The following is a description of a gene set: studied in species Homo sapiens Genes predicted to be targets of miRBase v22 microRNA hsa-miR-338-5p in miRDB v6.0 with MirTarget v4 prediction scores > 80 (high confidence targets). Human Gene Set: MIR338_5P from publication Chen Y, Wang X (PMID 31504780), and this is the list of marker genes: SLC25A12, ARHGAP12, LRATD1, BMI1, ENAH, ZBTB44, PICALM, CLIP1, DYRK1A, NDUFS2, TLK1, HOXA10 (homeobox A10), SLC25A53, DLGAP1, FRS2, ZFAND5 (NCBI Gene Id 7763), SCN2A, H3-3B, TSHZ3, KALRN, AZIN1, ABTB2, CHSY3, H3-5, CCNL2, OBI1, CNOT4, HSPH1, ATP11C, CAMTA1, ZNF711, SPRY4, HDAC4, SGK1, ATP2C1, ATOSA (NCBI Gene Id 56204), PTPN2, KLF10, GRID2, KIAA0408, NCK2, USP25, STRN, ARHGAP23 (NCBI Gene Id 57636), TADA2B, SPAST, DDIAS, ZNF770, CUL2, LIPT2-AS1, RICTOR, PREPL, LRRTM3, FPGT, PAIP2, MYCL, ATXN10, DYRK1B (NCBI Gene Id 9149), HSF2 (NCBI Gene Id 3298), CNOT6L, AIMP1, FZD7, BRWD3, SCML1, AP1B1, LEPROT, TRAT1, DDX46, EOMES, ACSL6, FGF2, NXPH2, CDC7, RORA, ACER3, CCDC6, TAOK3, MBNL1, CSRNP3, PDE10A, JMJD1C, DDX59 (NCBI Gene Id 83479), USP13, A1CF, GDI2, NR3C1, EBF3, DARS1, TAF7, FERMT2, CD9, YIPF5, FAM135B, WDR72, FBXO4, WWC3, WIF1, ID1, UTS2B, ZNF827, HOXA9, KLF2, UBE2K, ABCA8, COMMD3-BMI1, SDE2 (SDE2 telomere maintenance homolog), NPAT, TMX4, MYCN, POLR2M, GRIA2, HCN1, U2SURP, ID4, AFDN, ANOS1, FKBP14, IKZF5, POGLUT3, SCML2, HS6ST2, IL6 (NCBI Gene Id 3569), OSBPL8, ARIH1, KRTAP4-11, FBXO33, CCDC82, DSC3, GPATCH2L, OGFRL1, VCPIP1, KMT2C (NCBI Gene Id 80260), SLC5A7 (NCBI Gene Id 60482), DYRK4, CENPF, SLC4A7, CMAS, ADM, WDR3, SEC63, SENP7, CEP97, CXXC4, GABRG1, SCN9A (sodium voltage-gated channel alpha subunit 9), ZFX, FAM161A, AMOTL1, TUT4, DENND4A, TMPO, ZNF793, STAG2, IL19, JAM2, CREB3L1, LRP2 (NCBI Gene Id 4036), MBLAC2, RAB6B (RAB6B, member RAS oncogene family), TNPO1, LDB2, TARDBP, MAP3K15, LTV1, RING1, RAB1A, CEACAM5 (CEA cell adhesion molecule 5), RNF138, ETS1, LTBR, MEF2C, COG6, RLF, MYBL1, ZXDC, CEP44, OGT, HECTD2, PIGA, UQCRQ, ANKRD12, PCNP, BTBD1, DBT, LSM1, TMED5, MECOM, ADAMTS17, DOCK3, WDR20, CA2 (carbonic anhydrase 2), CEP63, ENPP1, NTF3, DPP8, ATAD5, TRA2B, ATP2B1, SYVN1, NAA15, HSPA5, RAB3C, RFX7, MAPK9, TRAPPC6B, ESRRG, CDNF, RPRD1A, MAP10, HACE1, FGL2, NBEA (neurobeachin), CSMD1, MBD5, KCNN3, CNTN4, RND3 (Rho family GTPase 3), GPA33, AAK1, MID2, HFM1, LRRC58, KCNJ3, GOLGA2, CD55, LRRC7, ADGRF5, EDIL3, FNDC3B, MAP4K3, DDX5, COBLL1, FEM1C, TBC1D12, ALG10B (ALG10 alpha-1,2-glucosyltransferase B), NAA25, KDM4B, SPTBN1, DGKH, TTC33, FOXJ3, DAAM2, LYPD6, MMP20, HIVEP1, ARHGAP5 (NCBI Gene Id 394), C2orf66, CCDC186, SOD2, PDHX, ZNF507, GYPA, TOB1, SLIT2, CTTN, KCTD15, MON2, SMG8, ANKRD44, WDR33, PRR12, LRRCC1 (leucine rich repeat and coiled-coil centrosomal protein 1), NF1, LATS1, ACBD5, CIRBP, SCAMP1, PDE4B, MED13, NXPH1, MAGI3, LIN54, PAN3, KMT5B, TBX2, FSD1L, NEUROD4, MARCHF6, CD300LD-AS1, SIRT1, MLANA, SLC49A4, TLR4, CEP104, CCL20, UNC13C, INTU, PKN2, DENND1B, TVP23B, SGMS1, GTF2A1, ADAMTS3, ARID2, EPHA5, BRDT, ZNF609, PIKFYVE, SLIT3, AHR, PHLPP1, COPS2, YY1, PHF20L1 (NCBI Gene Id 84165), CCDC126, CMTM4, IRF6, BCL2L11, ARL15, PPP6R3, SYPL1, ACVR2A, NSMCE4A, CPSF6, ARID5B, CHIC1, MYO1E, ESRP1, KAT2B, TAF1, RRM2, ANKS1B, EID1, FMNL2, ORC6, DAGLA, NEK4, SPRY2, ZC3H12C, SMAD5, CREB1, TAF6, LPCAT2, GTPBP2, ENPP2, HDAC9, KLF11, SOX6, TRPC1, BAHCC1 (NCBI Gene Id 79749), R3HDM2, SMURF2, CDK17, NR1D1, HOXA5, TASOR (NCBI Gene Id 51687), HESX1, SREK1IP1, SH2D1A, PJA2, RNF180, ETNK1, BBX, TMEM158, SOS2, CHM, ATP5MC3, RAB28, PTGDR, MTRR, GUCY1A1, STK3, ARID4B, ZNF521, BICD2, PURA, GCOM1, PTCH1, C1orf52, ZNF585A, NSUN7, POLR3G, ZFY, PTPRM, PTPN9, GATA3, DICER1, WASF1, PPP2R5A, TEC, RABGGTB, ALX1, PPP1R12A, PAQR3, NR5A2, B3GALT6, MAP3K2, PI4K2B, KRTAP4-8, MSTN, CADM2, ATP11B, ATP6V0A4, ITPR1, PELI1, PPP2R5C, IL22RA2, CUL4A (cullin 4A), UST, WDFY3, DNAJC6, CDK6, RHEB, HYCC1, LRP1, ATP7A, NUFIP2, FGFR1OP2, CAV2, NAB1, CDYL2, PPM1A, WDR47, HORMAD1, COL4A3, INO80D, CYP24A1, VMA21, UNC5D, MRPS18B, SYCP1, RB1CC1, ZMYM3, PHC3, GCNT2, BACH2, COX15, ATRN, MITF, ITGB2, IKZF4, HYCC2, MSI2, TXNDC11, SIX1, SP2, FST, GTF3C3, PARD6B, PALLD, PCDH20, FANCM, NSL1, CAST, GTPBP10, APCS, ARAP2, FEZ1, SP3, GABRB2, AK7, ACKR3, IFNW1, CCN2 (NCBI Gene Id 1490), GDAP2, BAZ2B, TENM1, ZNF543, SH3BGRL, NDFIP1, TET2, ZNF236, RANBP17, TAOK1, MNX1, XIAP, IKBIP, NEK7, MTF1, PRR11, CHD1, HEMGN, LSM6, BCL9, CATSPERE, RMI1, TSHZ1, CHORDC1